Given this list of marker genes UBQLN1, UACA, NONO (NCBI Gene Id 8253), NOL3, SOD2, HIF1A, MIR133A1, BAG5, PRKN, CYP1B1, P4HB, JAK2, ARL6IP5, ATF4, PRODH, PRKCD, PARP1, MMP2, IL10, DIABLO, WNT1, MELK, AKT1, MIR195, HSPB1, FZD1, RACK1, MAPK7, GSKIP, PDK1, NME5, MIR29B1, PPIA, PDCD10, PINK1, FBXW7, NOX1, MCL1, PML, VNN1, ADCY10, PARK7, FBXO7, NFE2L2, FGF2, SOD1, TRAP1, GATA4, TREM2, SIRT1, MIR19A, SFPQ, HTRA2, GPX1 (NCBI Gene Id 2876), DAXX, BCL2, MIR92A1, CTNNB1, STK25, MAP2K4 (mitogen-activated protein kinase kinase 4), INS, MAP3K5, FYN, PYCR1, STK24, ZNF622, here is a description of the gene set: species: Homo sapiens Human Gene Set: GOBP_INTRINSIC_APOPTOTIC_SIGNALING_PATHWAY_IN_RESPONSE_TO_OXIDATIVE_STRESS The series of molecular signals in which an intracellular signal is conveyed to trigger the apoptotic death of a cell. The pathway is induced in response to oxidative stress, a state often resulting from exposure to high levels of reactive oxygen species, and ends when the execution phase of apoptosis is triggered.